Given this list of marker genes Lce1d, Krtap13-21, Polr3g, Krtap1-5, Calm4, Pard6g, Krtap16-3, Sprr2a1 (NCBI Gene Id 20755), Pla2g2e, Krt71, Rdh10, Serpinb8, Krtap8-1, Ide, Krtap9-1, Tuba8, Id3, Sfn, Acp6, Adtrp, Id1, Bmp2, Mmp7, Tgm1, Bmp7, Gas7, Gltp, Scel, Atg9b, Ctps1, Ptbp3, Tubb3, Krt15, Krt25, Aox4, Gjb6, Krt85, Mal, Gata6, Clip4, Krt86, Padi1, Krt81, Vav3, Krt36, Cysrt1, Gjb4, Slc23a3, Mt4, Dst (NCBI Gene Id 98718), Dsc1, Gata2, Krtap4-16, Pinlyp, Gjb5, Asprv1, Hrnr, Rptn, Degs2, Slco5a1, Ly6g6c, Cadps, Lce1f, Krtap15-1, Krt34, Krtap3-1, Tnfrsf19, Sostdc1, Tgm3, Gnai1, Defb6, Krt16, Crct1, Krtap3-3, Stfa3 (NCBI Gene Id 20863), Tcf7, Gprc5d, Krt5, Hyal1, Cyp1b1, Serpinb11, Pou3f1, Ptch2, Krt33a, Serpinb9g, Cdsn, Dlx3, Cacna2d3, Krtap5-2, Krt72, Pawr, Krtap4-13, Padi4, Bmp4, Teddm3, Krtap4-2, Fgfbp1, Flg, Psors1c2, Msx2, Tchh, Krtap19-3, S100a14, Gja1, Krt35, Klf4, Cwh43 (cell wall biogenesis 43 C-terminal homolog), Fabp5, Sp6, Lce1i, Defb1, Krt17, Hoxc13, Mt2, Sncaip, Krt14, N4bp3 (NCBI Gene Id 212706), Gm13889, S100a3, Sprr2h, Ivl, Jag2, Krtap6-5, Cryba4, Cst6, Endou, Krtap14, Krtap6-2, Krtdap, Nfe2l3, Cux1, Acsbg1, Syt9, Notum, Sprr1a, Krtap9-22, Krt6b, Hopx, Krt6a, Wnt10a, Gpr87, Krt75, Wnt6, Krtap13-20, Nkd1, Serpinb2, Klk7, Krt1, Lce1a2, Ahr, Krtap19-9b (NCBI Gene Id 170939), Crym, Ralgps2, Elovl4, Acot1, Apcdd1, Egr2, Krt83, Krt31, Zfp703, Krt27, Sprr1b, Padi3, Trp63, Krtap13-1, Krtap9-3, Ovol1, Krt33b, Il24, Aqp3, Pim1, Klk6, Krtap6-3, Atp12a, Trim29, Krt10, Slc40a1, Casp14, Krtap21-1, Slc46a2, Rdh9, Gsdma, Limk2, Krt79, Spo11, Lce1a1, Lrp4, Krt80, Il36rn, Adh7, Axin2 (NCBI Gene Id 12006), Rasl11b, Irx4, here is a description of the gene set: Genes that have high expression in mammary tumors of squamous epithelium histology. Human breast cancer has been characterized by extensive transcriptional heterogeneity, with dominant patterns reflected in the intrinsic subtypes. Mouse models of breast cancer also have heterogeneous transcriptomes and we noted that specific histological subtypes were associated with particular subsets. We hypothesized that unique sets of genes define each tumor histological type across mouse models of breast cancer. Using mouse models that contained both gene expression data and expert pathologist classification of tumor histology on a sample by sample basis, we predicted and validated gene expression signatures for Papillary, EMT, Microacinar and other histological subtypes. These signatures predict known histological events across murine breast cancer models and identify counterparts of mouse mammary tumor types in subtypes of human breast cancer. Importantly, the EMT, Adenomyoepithelial, and Solid signatures were predictive of clinical events in human breast cancer. In addition, a pan-cancer comparison revealed that the histological signatures were active in a variety of human cancers such as lung, oral, and esophageal squamous tumors. Finally, the differentiation status and transcriptional activity implicit within these signatures was identified. These data reveal that within tumor histology groups are unique gene expression profiles of differentiation and pathway activity that stretch well beyond the transgenic initiating events and that have clear applicability to human cancers. As a result, our work provides a predictive resource and insights into possible mechanisms that govern tumor heterogeneity. Mouse Gene Set: HOLLERN_SQUAMOUS_BREAST_TUMOR from publication Hollern DP, Swiatnicki MR, Andrechek ER (PMID 29346386) species: Mus musculus